Given this list of marker genes PDE6C, ATF6, CNGB3, CNGA3, GNAT2, RPGR, AFG3L2, OPN1SW (NCBI Gene Id 611), FA2H, PDE6H, here is a description of the gene set: Human Gene Set: HP_COLOR_VISION_TEST_ABNORMALITY species: Homo sapiens Color vision test abnormality